Given this list of marker genes Kcne1, Rnf207, Cacnb2, Cacna1d, Cacna1c, Kcnj5, Kcne4, Cav3, Kcnq1, Ctnna3, Cacna2d1, Jup, Ank2, Pkp2, Dsg2, Dlg1, Cav1, Scn3b, Scn5a, Kcne3, Scn1a, Dsp, Trpm4, Scn2b, Dsc2, Kcna5, Bin1, Kcne5, Snta1, Ryr2, Kcnn2, Scn1b (sodium channel, voltage-gated, type I, beta), Kcnj8, Flna (NCBI Gene Id 245705), Kcne2, Gja5, Scn4b, Kcnh2, Kcnj2, Nup155 (nucleoporin 155), Nedd4l, Gpd1l (glycerol-3-phosphate dehydrogenase 1-like), Kcnd3, here is a description of the gene set: Mouse Gene Set: GOBP_CARDIAC_MUSCLE_CELL_ACTION_POTENTIAL_INVOLVED_IN_CONTRACTION An action potential that occurs in a cardiac muscle cell and is involved in its contraction. studied in species Mus musculus